The following is a description of a gene set: from publication Cui A, Huang T, Li S, Ma A, Pérez JL, Sander C, Keskin DB, Wu CJ, Fraenkel E, Hacohen N (PMID 38057668) Cytokines mediate cell-cell communication in the immune system and represent important therapeutic targets. A myriad of studies have highlighted their central role in immune function, yet we lack a global view of the cellular responses of each immune cell type to each cytokine. To address this gap, the authors created the Immune Dictionary, a compendium of single-cell transcriptomic profiles of more than 17 immune cell types in response to each of 86 cytokines (>1,400 cytokine-cell type combinations) in mouse lymph nodes in vivo. A cytokine-centric view of the dictionary revealed that most cytokines induce highly cell-type-specific responses. For example, the inflammatory cytokine interleukin-1β induces distinct gene programmes in almost every cell type. A cell-type-centric view of the dictionary identified more than 66 cytokine-driven cellular polarization states across immune cell types, including previously uncharacterized states such as an interleukin-18-induced polyfunctional natural killer cell state. Genes positively differentially expressed in cell type: Neutrophil upon treatment with cytokine: GM-CSF in mouse lymph nodes in vivo. studied in species Mus musculus Mouse Gene Set: CUI_NEUTROPHIL_GM_CSF_RESPONSE_UP, and this is the list of marker genes: Pnp, Fcgr2b, Rab44, Bcl2a1d, Xbp1, Tmem243, Fth1, Cish, Bcl2a1a, Upp1, Hbegf, Ffar2, Srgn, Basp1